Given this list of marker genes WNT16, TCF3, MACROH2A2, H19, WNT10B, FZD3, APC2, DKK4, SERPINF1, FZD8, AXIN2, CHD8, DVL3, LRP6, ATF3, TCF7L2, WNT2B (NCBI Gene Id 7482), SFRP5, WNT6, FZD10, LRP5, CER1, APC, NKD1, CTNNB1, CTNNBIP1, FZD9, NOTUM, CSNK1A1L, WNT5B, MAP3K7, WNT11, EZH2, DVL2, FZD6, WNT10A, CSNK2B, CDK6, RYK, LEF1, JUN, HNRNPK, TCF7, FZD5, PORCN, FOSL1, SFRP2, WNT3A, DKK1, CSNK2A1, SOST, SFRP1, MIR16-2, FRAT1, CXXC4, DVL1, GSK3B, FZD2, TCF7L1, SENP2, WNT2, CCND3, WIF1, CDK8, WNT1, TFAP2A, MIR675, NKD2, FRAT2, MYC, AXIN1, CCND2, SOX17, WNT5A, MIR16-1 (NCBI Gene Id 406950), CSNK1E, WNT3, ROR1, KREMEN1, FZD1, CSNK1A1, NLK, PLAU, WNT7B, CCND1, WNT7A, CSNK2A3, HNRNPU, CTBP2, FZD7, SFRP4, MIR34AHG, WNT4, CTBP1, ROR2, RUVBL1, CSNK2A2, DKK2, here is a description of the gene set: species: Homo sapiens lncRNA in canonical Wnt signaling and colorectal cancer Human Gene Set: WP_LNCRNA_IN_CANONICAL_WNT_SIGNALING_AND_COLORECTAL_CANCER